Given this list of marker genes HIVEP2, USH2A, DARS2, TMEM67, WHRN, PSEN2, GABRA5, HTRA2, ADSL, APC2, SACS, MYO5A, PIGG, NTRK2, SCN1B, MORC2, EXOSC3, SLC32A1, STX1A, GLB1, ZMIZ1, PLAA, MBTPS2, IBA57, OFD1, DPAGT1, CYB5A, POMT2, AP4E1, CLIP2, DNAJC13, RNU12, CAMTA1, AP4M1, POLA1, PGAP1, SCN3A, FGF13 (fibroblast growth factor 13), GTF2E2, VPS16, SYNGAP1, DGUOK, NAXD, MUC1, TRIM8, SOX10, IRF2BPL, PANK2, ESAM, NANS, SLC2A1, TCTN3, FH, GIGYF2, LARGE1, OCLN, PIGU, ALG9, TSEN15, PCCA, SERPINI1, GRIA2, MAGEL2, KIF1A, GFM2, TRAPPC9, AARS1, HUWE1, PITRM1, GRIA3, C9orf72 (C9orf72, member of C9orf72-SMCR8 complex), TMX2, TERT, CACNA2D1, WDR45, TANGO2, MAF, DKC1 (dyskerin pseudouridine synthase 1), WWOX, SLC38A3, POMT1, CYB5R3, SLC1A4, ATP1A3, OPHN1, SLC33A1, HTT, SNRPN, CASZ1, RNF113A, B3GLCT, CNTNAP1, CRLS1, UQCRC1, PSAP, VPS4A, KCNMA1, FUCA1, SLC39A14, PSPH, SCN8A, AHDC1, DYNC1I2, SNAPC4, DDB2, TRAPPC12, UBTF, MDH2, TARS1, ELOVL4, PQBP1, REPS1, HERC1, VPS41, CAPRIN1, CDK19, CACNA1B, SLC19A1, TRRAP, COG4, SLC31A1, TMEM70, KANK1, POGZ, BAZ1B, PIGA, ACTL6B, GMPPB, WNK3, GTF2IRD1, BMP4, PCYT2, KARS1, NUTM2B-AS1, FOXG1, NFU1, MT-CO2, TP53RK, BSCL2, COQ9, B4GALNT1, SUMF1, IARS2, HSPG2, BUB1, CTNS, CLN3, XPC, UBE4B, CNKSR2, NECAP1, CTSF, WDR73, PIGT, VARS1, SCN2A, ATXN7, TIMM50, KIF26A, CDKL5, FBXL4, ESPN, USH1C, TWNK, MAPK8IP3, RARS2, HTRA1, ERCC6, NUS1 (NCBI Gene Id 116150), RPS6KA3, PTDSS1, SCYL2, CLN6, ZNF335, NDE1, DMXL2, SIK1, PIGP, XPA, RNU4-2, ALG8, MYT1L (NCBI Gene Id 4662), NDUFA8, STX1B, TMEM147, RMND1, METTL27, SCN1A, ARX, ACD, UFM1, COG1, SETBP1, IFIH1, SHPK, AP3B2, SYT2, PARS2, RNASEH1, KIF1C, RNU7-1, COQ4 (coenzyme Q4), IKBKG, FTL, PRKN, ATP1A2, DTYMK, PEX16, WIPI2, TIAM1, SLC5A6, PRKCZ, ALG11, TOMM40, ITPA (inosine triphosphatase), CPLX1, VPS35, SPTAN1, FKRP, GRN, GRIN1, SEPSECS, TRNT1, DOCK6, FOXP2, NGLY1, COL18A1, MVK, MINPP1, SLC25A15, ATP5F1A, GTF2IRD2, CDC42, ADAM22, SPG11, SCN9A, PLCB1, VPS53, CASK, LRRK2 (NCBI Gene Id 399472), SUCLG1, JPH3, DHX30, PPP3CA, ATG7, ATAD1 (ATPase family AAA domain containing 1), GON7, BTD, PEX7, ALS2, NUP54, ATP11A, ERCC8, MT-TL1, PRUNE1 (prune exopolyphosphatase 1), INTS11, AP4B1, GOLGA2, TRAK1, PCLO, POU4F1, MYO7A, RTEL1, HCN1, SORL1, GRIN2A, KRAS, MT-ND5, KCNB1, GOT2, SMC3, ADGRV1, ZSWIM6, DPYD, LAGE3, ERCC1, MARS2, LHX1, EIF2AK2, CYFIP2 (cytoplasmic FMR1 interacting protein 2), GUF1 (GTP binding elongation factor GUF1), HSD17B4, NEUROD2, DOCK7, PUF60, STXBP1, FA2H, BRD4, TRAPPC6B, GABRB2, ACTB, PUS3, COASY, HECW2, COX4I1, PLA2G6, GABRA2, TPI1, FBXO28, TSEN2, SLC1A2, ATPAF2, PNKP, MT-CO3, USH1G, DNM1, SPG21 (NCBI Gene Id 51324), MRM2, VCP, AP1S2, ATP5MK, RAB3GAP2, EXOSC2, ACO2, SYNJ1, DNAJC30, CIZ1, PEX1, ACY1, GM2A, RAD21, POLR1A, NDP, UNC80, EIF2B4, POLR3A, RARS1, SLITRK2, ABCA7, DNAJC3, ABCD4, FASTKD2, HDAC8, KIDINS220, NALCN, ATP5F1E (NCBI Gene Id 514), LIAS, CYP27A1, PCK1, SLC35A2, ACER3, AIMP1, PRDX1, RTTN, KIF7, KMT2D, RFC2, HEPACAM, MMACHC, OCA2, FMR1, MED25, GALC, TRIT1, GJC2, KCTD7, TMCO1, SLC2A3, DYRK1A, MOGS, MT-ND6, PIGQ, CLPB, BCS1L, SLC17A5, TDP1, CTSD, DSE, GLYCTK, AUH, SCO2, PRRT2, AIMP2 (aminoacyl tRNA synthetase complex interacting multifunctional protein 2), GTF2H5, KCNC2, POLG, SHQ1, NADK2, RNF125, MT-CO1, FADD, YWHAE, AP4S1, GABRG2, TREM2 (NCBI Gene Id 54209), MT-TH, BCAP31, PCCB, PUM1, YIF1B, FRMPD4, SNORD118, SPEN, PPP2R2B, GABRD, FGFR1, SLC35C1, TTC5, ALG13, QARS1, MAN2B1, EIF4G1 (eukaryotic translation initiation factor 4 gamma 1), VPS37D, GNPTAB, ATP13A2, TYROBP, SUOX, POLR3B, NAGA, LIMK1, PPFIBP1, TAF6, CWC27, ERCC2, TGFB1, DMPK, PPT1, NDUFAF5, PRNP, LYRM7, POLG2, WARS2, MT-ATP8, NT5C2, HNF1B, MAP2K2, GPKOW, PHACTR1, WFS1, ATN1, LMNB1, SLC13A5, PARN, FDXR, DNM1L, PTCD3, GRM7, KDM5A, LSM11, NDUFB8, OPA1, NAA10, MED17, FZR1, GET4, MT-TS2, SLC25A46, MMP23B, NDUFA9, YRDC, SUCLA2, SLC9A6, MOCS2, COLGALT1, TBC1D20, KCNA2, CARS1, CHMP2B, HIC1, MPDU1, FAR1, NRROS, MTR, GRIN2D, MTRR, DHCR7, FLI1, PRKAR1B, EMX2, NDUFA2, ERCC3, HACE1, SQSTM1, DPM1, MT-ATP6, AIFM1, SMARCC2, MOCS1, OSGEP, STAMBP, LIPT2, COG7, TREX1, EEF1A2, TARS2, MAP2K1, CNTNAP2, RALGAPA1, MED27, AP1B1, ERCC5, SMG9, PDPN, CTDP1, KCNH5, CLN8, TTC19, NIPBL, NUP133, GABBR2, GDAP2, PCDH15, NFIX, FBLN1, NKX6-2, RAB23, CTCF, CCDC47, DDX3X, NDN (necdin, MAGE family member), CISD2, KCNQ2, GLE1, GBA2, NEK1, SKI, MT-ND4 (NCBI Gene Id 4538), CACNA1A, HSD17B10, UCHL1, ADAR, AGTPBP1, RNF216, PAFAH1B1, KDM6A (NCBI Gene Id 7403), EPG5 (ectopic P-granules 5 autophagy tethering factor), CARS2, TPP1, UGP2, MMADHC, ADA2, PIGS, ALDH18A1, BICRA, NSD1, CDH23, OSTM1, APOE, RAB18, ATRX, EHMT1 (NCBI Gene Id 79813), AP3D1 (NCBI Gene Id 8943), ERCC4, CELF2, TRAPPC2L, COQ2, SLC12A5, PACS2, BICD2, CLCN4, NUP62, TRAPPC11, CIB2, MECR, PRDM16 (NCBI Gene Id 647868), AGA, EPRS1, ATP8A2, PIGL, AFG2A, EXOC7, POLR3K, SZT2, GTF2I, YWHAG, HDAC4, TIMM8A, DALRD3, EXOSC5, DHFR, NOVA2, RNU4ATAC, TK2, PDE6D, PDHA1, APP, VRK1, GNAO1, PLK4, TBCD, RNASEH2A, COG5, UBE3A, KCNT1, EXOSC8 (NCBI Gene Id 11340), TMEM270, GRIA4, SPG7 (SPG7 matrix AAA peptidase subunit, paraplegin), TUBGCP4, STAG1, SMC1A, OTUD6B, PCDHGC4, RNASEH2B, TRAF7, KCNAB2 (NCBI Gene Id 8514), ATP6V1A, SLC39A8, DHDDS, VPS13A, ALG3, TOE1 (NCBI Gene Id 80147), SLC39A4, BRAF, LONP1, MPLKIP, ALG14, TRPM7, MT-TF, TBP, ZC4H2, FARSB, BUD23, UBA5, TSEN54, LUZP1, ELN, ADNP, GNAQ, NMNAT1, L2HGDH, COG6, KCNA1, ALG1, RHOBTB2, ATP5F1D, MT-ND1, MFSD8, SNX14, ADK, TAF2, RAB3GAP1, AMPD2, DCDC2, RERE, KY, GCDH, MT-TW, PDZD7, ITPR1, ZFX, CSF1R, HEXB, TECPR2, EIF4H, TBC1D24, CPA6, HRAS, CACNA1E, PYCR2, CHCHD10, MECP2, CLP1, ZNHIT3, PDHX, ATXN2, MT-TQ, ATP6AP2, FRRS1L, COG2, CLTC, PIGN, SIX3, NACC1, TUBGCP6, NCF1, FGF12, VPS13C, NUP214, TMEM106B, TBCK, ASNS, TBL2, BCAS3, IFT56, ADARB1, CLN5, TBK1, RBL2, SLC35B2, SNCA, FKBP6, EMC1, PSEN1, GAD1, GBA1, ACTG1, MED11, NEXMIF (neurite extension and migration factor), SLC25A22, FARS2, MAG, H3-3A, NODAL, PEX19, PIGV, MAPT, STUB1 (NCBI Gene Id 10387), EXOSC1, DNMT1, PMPCA, RFT1, ROGDI, TINF2, ADPRS, MEF2C, CPSF3, EXOSC9, here is a description of the gene set: Human Gene Set: HP_ATROPHY_DEGENERATION_AFFECTING_THE_CEREBRUM species: Homo sapiens Atrophy/Degeneration affecting the cerebrum The presence of atrophy (wasting) of the cerebrum, also known as the telencephalon, the largest and most highly developed part of the human brain.